Given this list of marker genes ATM, UBE2B, TERB1, SPO11, TERB2, MLH1, KASH5, SPDYA, TERF1, SUN1, MAJIN, NUP98, here is a description of the gene set: Human Gene Set: GOBP_TELOMERE_LOCALIZATION Any process in which a telomere is transported to, and/or maintained in, a specific location. studied in species Homo sapiens